The following is a description of a gene set: studied in species Homo sapiens During meiosis the replicated chromosomes of a single diploid cell are segregated into 4 haploid daughter cells by two successive divisions, meiosis I and meiosis II. In meiosis I, the distinguishing event of meiosis, pairs (bivalents) of homologous chromosomes in the form of sister chromatids are paired by <b>synapsis</b> along their regions of homologous DNA, and then segregated, resulting in haploid daughters containing sister chromatids paired at their centromeres. The sister chromatids are then separated and segregated during meiosis II.<p><b>Recombination</b> between chromosomal homologues but not between sister chromatids occurs during prophase of meiosis I. Though hundreds of recombination events are initiated, most are resolved without crossovers and only tens proceed to become crossovers. In mammals recombination events are required between homologues for normal pairing, synapsis, and segregation. part of: Cell Cycle; Reproduction Reactome Pathway: Meiosis, and this is the list of marker genes: H4C1, MSH5, MSH4, H2AC14, TERF1, SPO11, H3-3A, NBN, DMC1, TERF2, H2BC26, H2AC4, BLM (BLM RecQ like helicase), H2BC3, ATM, H3C1, UBE2I, H2BC11, H2BC12L, SUN2, SYCP1, SYNE2, LMNB1, RAD51C, SYNE1, H2AZ2, FKBP6, H2BC14, FIGNL1, H2AB1, TEX15, H2BC15, SMC1B, ATR (NCBI Gene Id 57307), BRCA1, SMC1A, SUN1 (NCBI Gene Id 80226), H2BC1, H2AX, SYCP3, MLH1 (mutL homolog 1), H2BC9, H2AC18, H2BC12, SMC3, H2AJ, SYCE3, RAD50, H2AC6, LMNA, MLH3, RPA2, TERF2IP, SYCP2, STAG3, CDK4, RAD21, RAD51, H2BC13, H2AC7, H2AC20, SYCE1, RBBP8, STAG1, HSPA2, RPA3, H2BC21, H3-4, TOP3A, REC8, H2BC4, BRCA2, MRE11, PSMC3IP, H3C15, PRDM9, FIRRM (NCBI Gene Id 55732), TINF2, SYCE2, STAG2, H2BC17, H2BC5, ACD, DIDO1, MND1, RPA1, CDK2, TEX12, POT1